Given this list of marker genes Tnc, Nav2, Nepn, 2300002M23Rik, Vwc2, Egflam, Igf1, Mamdc2, Smoc2, Ecm2, Abi3bp, Kazald1 (NCBI Gene Id 226156), Ccdc80, Vit, Col14a1, Adamtsl4, Vwa1, here is a description of the gene set: Mouse Gene Set: GOCC_INTERSTITIAL_MATRIX A type of extracellular matrix found in interstitial connective tissue, characterized by the presence of fibronectins, proteoglycans, and types I, III, V, VI, VII and XII collagens. studied in species Mus musculus